Given this list of marker genes Cacnb2, Arfgap3, Ctbp2, Amph, Egflam, Cltc (clathrin heavy chain), Cplx3, Dag1, Hspa8, Atp2b2, Cdh23, Atp2b1, Lrrtm4, Dnm1, Pacsin1, Iqsec2, Sh3gl2, Rims2, here is a description of the gene set: studied in species Mus musculus Mouse Gene Set: GOCC_PHOTORECEPTOR_RIBBON_SYNAPSE A ribbon synapse between a retinal photoreceptor cell (rod or cone) and a retinal bipolar cell. These contain a plate-like synaptic ribbon.